The following is a description of a gene set: species: Homo sapiens PERK regulates gene expression Human Gene Set: REACTOME_PERK_REGULATES_GENE_EXPRESSION, and this is the list of marker genes: EXOSC3, DDIT3, EXOSC2, NFYB, HERPUD1, EXOSC5, EIF2S3, NFYC, EXOSC6, EXOSC7, CEBPB, EXOSC4, IGFBP1, PARN, CXCL8, ASNS, NFYA, EIF2AK3, HSPA5, DCP2, EXOSC8, CEBPG, ATF6, DIS3, EXOSC1, EIF2S1, ATF4, KHSRP, EXOSC9, EIF2S2, CCL2 (NCBI Gene Id 6347), ATF3